Given this list of marker genes Ccnt2, Brd4, Gtf2h2, Mnat1 (NCBI Gene Id 320958), Rb1, Ccnh, Cdk13, Gtf2h4, Gtf2h1, Gtf2h3, Ercc3, Ccnk, Cdk12, Ercc2, Cdk9, Cdk7, Gtf2h5, Tex24, Psmc5, Ccnt1, Snw1, Gtf2f2, here is a description of the gene set: Mouse Gene Set: GOCC_CARBOXY_TERMINAL_DOMAIN_PROTEIN_KINASE_COMPLEX species: Mus musculus A protein complex that phosphorylates amino acid residues of RNA polymerase II C-terminal domain repeats; phosphorylation occurs mainly on Ser2 and Ser5.